The following is a description of a gene set: Mouse Gene Set: GOBP_COMMON_BILE_DUCT_DEVELOPMENT studied in species Mus musculus The progression of the common bile duct over time, from its formation to the mature structure. The common bile duct is formed from the joining of the common hepatic duct running from the liver, and the cystic duct running from the gallbladder. The common bile duct transports bile from the liver and gallbladder to the intestine., and this is the list of marker genes: Gak, Hes1, Hhex (NCBI Gene Id 15243), Notch2, Mir30a, Sox9, Sox17, Mks1